The following is a description of a gene set: species: Homo sapiens from publication Chen Y, Wang X (PMID 31504780) Human Gene Set: MIR9718 Genes predicted to be targets of miRBase v22 microRNA hsa-miR-9718 in miRDB v6.0 with MirTarget v4 prediction scores > 80 (high confidence targets)., and this is the list of marker genes: TMEM184A, HMGB3, LAPTM4B, CHAMP1, ARHGAP36 (Rho GTPase activating protein 36), CCDC146, WDR64, FXYD6, ZDHHC1, STK40 (NCBI Gene Id 83931), CD80, ZSCAN22, ATP2A2, MEF2C, AHCYL2, CAMK4, KDM5B, SALL1, GPR15, ZC3H6, PRKAB1, PTN, BNIP3L, DCX, ZSCAN31, BIRC6, PITX2, FAM168B, TMEM33, ATXN3, RABGEF1, AP4E1, PLD5, NPEPPS, G6PC1, PVRIG, SCN3A, RAG1, NBEA, SLC46A3, FAM210B, ZNF426, KATNAL2, ANK3, ANKRD50, TCF21, SLIT2, DYRK1A, CCDC144NL, EMILIN3, WDFY3, CHPT1, IKZF1, VASH2, PSD3 (pleckstrin and Sec7 domain containing 3), RLF, TMEM185B, FUT9, FNDC5, COL19A1, CISD1, EPHA3, NFATC1 (NCBI Gene Id 4772), LSM14A, DDX59, LMLN, TRAF3, STK32B, TSNAX, ATG4A, MRAP2, ELOVL1, OTULINL, DEK, TXNDC16, ELAPOR2, SLAIN1, ZBTB21, DMC1, SSH1, PRTG, BBS1, TIMM23B, CAV1, NAT2, RORA, CRYGN, SMARCAD1, BCL6, LEPROT, COL4A1, NR1D2, ZMAT4, SLC26A4, EFR3A, PSTPIP2, LOXL3, ADGRE2, ACVR1, BLM, GEMIN2, COG6